Given this list of marker genes FSTL1, ALOX5, HLA-DMA, MYL12A, CBR1, AMOTL2 (angiomotin like 2), VMP1, CFB, CTNNA1, MAPKAP1, DDAH1, EGLN1, SLC40A1, NPNT, MAT2B, C5AR1, COX7B, SH3D19, BTG1, GADD45A, PAH, GM2A, NECAP2, HLA-DRB1, RNPEP, C1R, ARHGAP12, SERPING1, MAOB, CLDN23, TNFRSF21, HLA-C, CAPN6, DUSP4, SPTSSA, ZSWIM6, SDCBP, UQCRH, ANXA2P2, MAP4, KLF5, CNN2, CYBB, TPBG, PTP4A1, SLC20A1, LAPTM4A, UQCRC2, SPSB1, TRIOBP, ACTR2, BRI3, PDLIM1, ZNF208, WWTR1, LBR, CA2, CDR2, EIF4EBP2, ACADVL, JAG1, RNF19A, ATP1A1, C3, TMEM87A, IGF2BP2, TMEM106B, CLDN2, VGLL3, CDKN1A, KLF6, NPAS2, LGALS9, MS4A7, LAMB3 (NCBI Gene Id 3914), FLII, UQCRFS1, ENAH, IMPA2, TFPI, TSHZ2, PIK3AP1, CTTN, TIPARP, COL18A1, CYP51A1, HSPB8, CAPZA1, LPCAT2, ANO6, SLC66A3, ZNF217, SYPL1, BCL10, UBE2L6 (ubiquitin conjugating enzyme E2 L6), RIPK2, CEBPB, CASP10, DCTPP1, RHOC, CHST15, PPIA, TRIM8, CDKN2B, FYB1, FCER1G, MET, YWHAB, EPRS1, IDH2, TMEM41A, TOB2, TMEM132A, AKAP13, FAM133CP, TCP1, FZD5, ERBB3, JPT1, DHRS3, MYL12B (myosin light chain 12B), BCL3, HLA-A, SPATS2L, CTSE, TMEM87B, AFAP1, SETD7, CSRP1, ZBTB20, PKHD1, LAMB1 (laminin subunit beta 1), ADAM10, MALL, CARHSP1, ARL6IP5, CHP1, DDAH2, SPRED1, SERPINA6, MAP3K20, ZNF704, HCK, PDGFD (NCBI Gene Id 80310), TJP2, VAT1, UTRN (utrophin), SLC6A20, CXCL8, PPDPF, IL17RD, GPRC5B, CDK2AP2, ALDOA, TRIP10, CLDN1, ST3GAL1, EZR, TRIM25, CCT2, ARHGAP21, CTSL, ABRACL, SRGN, TMC4, SFRP5, RALA, MSMO1, LACC1, PMP22, NAMPT, PPP1CB, KANK2, KRTCAP3, ANKRD13A, IFI30, IL1R1, UGT2A3, MPRIP, OPTN (NCBI Gene Id 337928), HINT3, SMARCC1, MYD88, EHD4, TINAGL1, SNAP23, ZNF267, HDGF, LURAP1L, IL1RN, CDS1, KNOP1, PACSIN2 (NCBI Gene Id 150377), ITGA6, HADHB, IFITM3, LGALS8, TNS1, NCEH1, YBX3, TGM2, SDS, DGLUCY, SLC25A24, TMEM127, GNS, TMC5, RAC1, SMURF1, MYO1E, CGNL1, EFTUD2, NNT, CNPPD1, BAIAP2L1, EGR1, TUBB6, DUOX2, PTPN14, FAT1, SPNS2, PSMB8, CXCL16, PPP1R11, AKR1C3, SOX10, PRR15L, NDFIP2, ANKRD9, DOCK1, GPX1, CREB5, ID2, BAZ1A, TM2D2, CXCL1, ABHD4, MUC1, TRAK2, REST, MAFF, MGAT4B, CFAP221, PNKD, NFKBIZ, SWAP70, HES1, CDX2, CTBP2, ETS2, SERINC2, TMBIM6, LTB, MSN, TNFAIP3, ACTR3, FGF19, MAPK6, ARPC2, SDHB, TACC1, RERG, ARHGAP29, ACAA2 (acetyl-CoA acyltransferase 2), TCF7L2, CDH1, STK38, ACSS2, CASK, RUNX1, PDE3A, MAP3K21, ATP5F1B, TTC9, FGFR2, ATP5MC3, UGT2B15, S100A13, EIF4E2, TPM4 (tropomyosin 4), KDM5B, CPM, C4orf19, NCOA7, EIF4G2, GLIS3, CRYZ, DIAPH1, ADCY5, NCK2, C1QB, EPCAM, TNFAIP2, RAP2B, AFDN, GULP1, ATP1B1, RAB5B, HEBP2, ANXA1 (NCBI Gene Id 301), SNX6, IGFBP7, SLPI, FTH1, LMNA, PRDX1 (NCBI Gene Id 5052), HLA-F, FGF2, OLR1, ZNF83, SLC35F6, BHLHE40, CEMIP2, RBP1, PPIF, LAD1, DUSP23, CNN3, ELOVL1, CA12, SIAE, ADM, SQSTM1, TMSB10, PDE5A, LIMS1, ITGA2, PTPRK, MRPL15, DYNC1I2, ATP2B4, MYADM, RAC2, HTATIP2, GALNT3, SLC25A5, YAP1, HIP1, HLA-DRA, RAB25, HDHD3, DUSP6, RCAN1, ASAP2, BICC1, UGP2, FLNA, SOWAHC, APBB1IP, FLRT3, CEACAM6, ARPC5, ANXA11, COX5A, HMGCS1, KDSR, TEAD2, AKR1B10, ERRFI1, SPP1, MPEG1, PHLDA1, GALNT2, MAGI3 (membrane associated guanylate kinase, WW and PDZ domain containing 3), APEX1, ACAA1, ATF3, GSTT1, SERPINA5, ZNF117, ERO1A, CRIM1, QSOX1, CAPG, PPARGC1A, STAU1, HNRNPF, ALDH1A3, HEBP1, CFI, SDC1, PBX1, WWC1, SOX9, CLN8, ASS1, SLC34A2, PEA15, DECR1, CEACAM7, PTMA, CDC42EP1, CFTR, ACTG1, FRMD8, BPGM, GOT2, TUBB, TFPI2, TFRC, GSTO1, MYO5B, TFF2, DOK5, RALB, DAG1, COX6A1 (cytochrome c oxidase subunit 6A1), PGK1, B4GALT1, TANC1, ALDH3A2, PRDM16, TGFB2, CSF1, CAP1, HLA-DRB6, KRT7, SULT1C2, SMS, HCP5, TYROBP, DEFB1, TRIM38, F2RL1, WBP2, CFLAR, HPCAL1, RAB32, SYK, CD300A, CLDN4, ARPC3, CLINT1, DCDC2, JCAD (NCBI Gene Id 57608), ITIH5, PIK3IP1, TGFA, BAMBI, RESF1, SEL1L3, CASP4, OSMR, ODC1, ARHGEF40, CYCS, PPIC, NUAK2, VAV3, RPS6KA2, MELTF (NCBI Gene Id 90031), RHOQ, LRATD2, SLC12A2, UGCG, IFNAR1, MIR4435-2HG, S100A10, WDR1, PPP2R3A, HNF1B, TNFRSF11B, ACOT9, MOB3B, SH3BP4 (SH3 domain binding protein 4), IGSF6, GOT1, TNFSF10, CXCL5, DUSP16, AHR, NINJ1, ZNF503, HKDC1, HLA-E, SLC25A23, CD2AP, PLS1, IQGAP1, PTGFRN, DLD, CCDC50, UBALD2, EFNB2, ARHGDIB, CD9, SH3YL1, ARL6IP1, CRP, NCOA4, RAB6A, ARHGAP26, SUSD6, PRR13, SPAG1, DAZAP2, LAPTM4B, GCC2, ZDHHC3, TIMP3, ANXA5, RNF44, CCN1, B3GNT7, TAPBP, DHCR24, TTL, LGALS4, TMEM98, AGAP1, DUSP5, GSN, SEMA6A, LEPROT, EXT1, TLE1, SH3BGRL3, STK38L, RCC2, RETSAT, TNFRSF1B, OCLN, GUCD1, PDLIM3, KCNK5 (potassium two pore domain channel subfamily K member 5), NTN4, CTTNBP2NL, C1QC, SYNE2, WASHC4, ZDHHC7, TNFRSF10B, AGT (angiotensinogen), HLA-DMB, HSD17B11, MINDY2, LGALS3BP, XRN2, IGSF3, LDHA, SEPHS2, KCNJ15, DTX3L, EPS8L3, CYP3A5, PPFIBP1, NHERF1, ABTB2, DSC2, FAM171A1, ANXA3, VASN, SFPQ, G6PC1, TPI1, MUC20, CPPED1, NHSL3, MGST3, VAMP8, GJA1, SESTD1, HMGB1 (high mobility group box 1), ASAH1, PLSCR1, SLC17A4 (solute carrier family 17 member 4), ZFP36L1, PNP, NRAS, TGFBR2, CYFIP1, BTBD7 (NCBI Gene Id 55727), PFKP, MID1, TIMP2, NEAT1, CCDC198, SLA, SYT8, EPB41L1, CRYBG1, KLHL24, CTSS, RSU1, TM4SF1, ITGB5, STK17B, LMO7, ONECUT2 (one cut homeobox 2), TRIB1, NPC2, ADGRF1, ITGA3, CXCL2, SMC5, TUBB4B, LMO4, GADD45B, MTUS1, B3GNT5, PRSS23, STARD7, CYP1A1, C6, HMGN1, HLA-DQA1, CFH, ARHGEF18, LYPD1, CAPN2, HNRNPAB (NCBI Gene Id 3182), WFDC2, SLC39A1, LRRFIP1, GATM, MMP7, CXADR, DYNLT1, LRRC8A, LCN2, PFN1, GBP2, FRMD4A, MAL2, C1RL, ARL4C, PTTG1IP, KCNQ1, TXN (thioredoxin), PTAFR, NDUFS2, EDN1, GSTK1, KRT80, GALNT7, ABCC4, GJB1, GMNN, C1QA, RASEF, LPAR6, PIGR, ZFP36L2, PTPRM, RB1CC1, ARF6, UBAP1, PGM2L1, CTSB, GDF15, POF1B, ABI1, MITF, CCNG2, RHOU, PAIP1, SATB1, WDR72, RHBDF1, TACSTD2, RDH11, TMEM165, NARS1, SDC4, GNPTAB, LUZP1, TBXAS1, CXCL3, ARSD, CLMN, ALDH3B1, KIAA1217, ACP5, CCND1, IER5, FUCA1, GSTM4, MCL1, AKAP7, ERGIC1, RPS27L, FNDC3B, CAV1, STAB1 (NCBI Gene Id 23166), ETV6, EIF2S3 (NCBI Gene Id 8422), SYNPO, PTPN12, CCL20, FCER1A (NCBI Gene Id 2205), MYO10, SLC38A1, TPGS2, CD47, ATP5F1C, MLPH, EGFR, SUCLG2, LINC01133, NECTIN2, SNHG12, NFKBIA, CDK6, TC2N, OCIAD2, FUT4, CCN2, SAV1, MBD2, CYP4V2, VASP, TNFSF15, CRCT1, TRIM47, SERINC5, VCAM1, ABCB1, CCL28, RCN2 (reticulocalbin 2), PSMB10, VNN1, CDR2L, PTPRC, ATP8B1, SNX10, TSPAN14, ZFP36, CHMP2B, CLIC1, YWHAZ, CD68, XRCC5, SAMD9, SLC12A7, RBM47, RAB10, LAMA5, HSPA1A, FILIP1L, CASP7, JOSD1, TM7SF3 (transmembrane 7 superfamily member 3), CAV2, STAT6, OLFM4, SLC3A1, SRGAP1 (NCBI Gene Id 57522), MTMR12, KRT18, PTMAP11, TGIF1, LPGAT1, THSD4, IFI16, ACTN4, DERL1, ALOX5AP, SERPINA1, LYN, AKR1C1 (NCBI Gene Id 9418), NRP1, HABP2, PGM2, ABCA1, SERPINB2, TPSAB1, LCP1, SMAD3, FA2H, RAPGEF5, H3-3B, SERTAD2 (SERTA domain containing 2), RASSF4 (Ras association domain family member 4), CD44, LRP10, PDCD6IP, SGPP1, NEURL3, APCS, PLA2G7, KRT19, LHFPL2, EEIG1 (estrogen-induced osteoclastogenesis regulator 1), CD74, NDRG2, GLO1, PAK1, CDH6, PSAP, NFIA, PWWP3B, CCL3 (C-C motif chemokine ligand 3), B4GALT4, CTNNB1, ADGRG6, RHOB, ABHD2, TAGLN2, ITPR2, ATP11A, AMOTL1, TGFBI, HLA-DPB1, APP, APOL1, CCDC71L, C1orf116, ITGB1, CHML, TST, CANT1 (NCBI Gene Id 619513), LAMC2, LIMA1, PMEPA1, FAHD1, ADGRA3, GLB1, LGALS3, ELOVL7, VDAC1, TOP2B, A2M (alpha-2-macroglobulin), LRG1, CTSO, ACSS1, H19, IL6ST, ADAM28, CEACAM5 (NCBI Gene Id 1048), VSIG4, RHOG, MYO1C, S100A14, HEG1 (NCBI Gene Id 57493), AHNAK, DHRS7, INSIG2, NR5A2, EIF6, EBP, NET1, SH2D4A, VCL, NTRK2, TMPRSS2, ANXA4, ERBIN, SLC44A2, SCNN1A, SYNCRIP, CITED4, GLUL, KRT17, CSTB, TP53INP2, ALAD, RMND5A, ARHGAP18, MACC1 (MET transcriptional regulator MACC1), NCAM1, TSPAN8, NMT2, CALD1, HOMER2, MDK, ATP11B, MARCKSL1, TRIM26, RAB27B, KRT23, SLC16A7, ERICH5, KIT, EFNA1, DDIT4 (NCBI Gene Id 54541), JUN, NR0B2, PLAU, TES, PDGFC, CBX3 (chromobox 3), SP100, TUBB3, DCBLD2, TP53I11, TXNIP, WSB1, THBS1, IFIT3, NFE2L2, KRT8, PHLDA2, MYOF, NDUFA6, CD24, RNASET2, SCAF11, SPTAN1, FGFR3, HS3ST1 (NCBI Gene Id 9957), TMEM50A, AQP1, RNASE1, RASSF8, GATA6, GRB2, LITAF, STS, DST, MAP1LC3B, PIM1, TOP1, SDHA, TUBA1C, SINHCAF, CHD4 (NCBI Gene Id 1108), FH, GYPC, WNK2, ATP13A3, IGF2R, LAPTM5, CFL1, FARP1, SLC46A3, ITGB2, TFF1, PROM1, HADHA, LLGL2, ABCC3, FNDC4, SKIL, MPC1, SP1 (NCBI Gene Id 6667), TMBIM1, LGR4, HLA-DQB1, PSME3, TBC1D16, TTN, BACE2 (NCBI Gene Id 25825), SIPA1L1, WEE1, F11R, TNFAIP8, HBEGF, LYPLA1, NECTIN4, AGPAT3, RNF213, GDE1, APCDD1 (NCBI Gene Id 85500), ENC1, MGAT5, ABCF1, CLIC4, CD63, PTPRF (NCBI Gene Id 5792), PLAUR, ADAM9 (NCBI Gene Id 8754), CHI3L1, SAT1, HGSNAT, STK24, ID3, CAT, PERP, PRKCA, PLS3, IFNGR2, MYH9, NFIX, NIPSNAP2, KLF13, MPZL1, DAPK1, CD84, TNKS1BP1, LIPH, RNF103, ABHD11, NEXN, FMNL2, MYH14 (NCBI Gene Id 79784), AMBP, BAAT, LIPA, PTP4A2, MSR1, UBD (ubiquitin D), SLC1A1, EPHA2 (EPH receptor A2), CAST, LMAN2, APOL6 (apolipoprotein L6), NCL, SLK, B4GALT5 (beta-1,4-galactosyltransferase 5), FAM110C, ALDH2, SUCLG1, ARPC1B, KIF13B, SRP14, SPTBN1, CTSC, C1S, NR1H4, FGD6, IFITM2, HNMT, HLA-DPA1, LAMC1, OXSR1, TUT7, ACSL4, ANK3, RAB9A, SORBS2, S100A6, CMTM7, SYNGR2, TNFRSF12A, CYC1 (cytochrome c1), C1orf198, LAMP2, SPRY2, NR2F2 (NCBI Gene Id 7026), SPINT1, TPM1, ERLIN2, MUC13, IQGAP2, NFIB, PLXNB1, FLRT2, ATP10B, TMEM43, IL18, PDLIM5, MLEC (NCBI Gene Id 9761), LIF, EHF, PDZK1IP1, PDP1, GBP3, FGA, KIF1C, PLEKHA2, STOM, CTSD, OGA, TMSB4X, ST6GAL1, RDH10 (NCBI Gene Id 157506), DUSP1, ICAM1, SOD2, CSF1R, BDH2, HDAC7, HSD17B2, TMOD3 (NCBI Gene Id 29766), VTCN1, LBH, ARRB2, NDUFA4, TP53BP2, NEDD9, COX5B, IER2, FDFT1, ARHGEF12, CES1, BCL2, HEXB, PON2, PAWR, RALGAPA2, HK1, NIBAN2, EPS8, LPP, NOTCH2, CYP1B1, MYRF, ANKRD1 (ankyrin repeat domain 1), SLC4A4, ELF3, STX7, UPK1B, NCF2, AGR2, NEDD4L, PAK2, SHROOM3, RRAS2, LANCL1, ABHD3, RBPMS, SLC38A2, GSTP1, ETFA, LASP1, FBLIM1, GPX2 (glutathione peroxidase 2), CERS2, MAGI1 (membrane associated guanylate kinase, WW and PDZ domain containing 1), NOP10, NLN, RGS1, NOTCH2NLA, APLP2, CXCL6, IL10RB, ELF1, PAFAH2, CMTM3, CNDP2, GNG5, RND3, KLF3, CD59 (CD59 molecule (CD59 blood group)), PFKFB3, ITGB4, PARD6B (NCBI Gene Id 84612), STK17A, GPNMB, VDAC2, MACF1, HSD11B2, PARD3, ITGB8, EXOC6, SIRPA, TSPAN15 (tetraspanin 15), CALM2, RAB11FIP1, S100A11, PHLDB2, TMEM51, CYTH2, PLEKHB1, CPT1A, SOX4, PIGS, TTYH3, QKI, DAB2, CREG1, BIRC3 (NCBI Gene Id 330), RUNX3, ITGAV, SLC35B2, PCSK5, MCAM, TMEM123, PICALM, SERPINA3, PRSS22, ADI1, CASP6, CLDN10, CCL2 (NCBI Gene Id 6347), CIAO2A, TSPAN3, RNF128, ALKAL2, PSG4, ZYX, ANXA2, GRN, ANXA9, PARP4, PIK3R1, MYO6, CCDC6, PNRC1, LDLR, FTH1P3, FGL2, BMP2, TBC1D5, BZW1, B2M, CRYAB, DSG2, CD151, LAMA3, ADAMTS9, PARP14, NGFR, ZNF292, MST1L, CTSH, HLA-B, KLHL5, SLC44A4, CCN3 (cellular communication network factor 3), NAPG, ZC3H12A, ATP5PO, CDH19, ACTB, GALNT1, KCNJ16, NAGK, TNS3 (tensin 3), CMPK1, KIAA0930, CS, HIF1A, JUP, SVIL, PRKX, GCNT3, SLFN5, BCL6, CAPN1, VPS26A, TCIM, DDX52, CLDN7, PLD1, UCA1, PPP1R18, SLC43A3, TXNRD1, CD53, PCYOX1, SLC15A1, IL4R, SLC25A3, CD276, ADAMTS1, ATP5F1A, OSBPL1A (oxysterol binding protein like 1A), SLC28A3, TPD52L1, GOLM1, FOXO3 (forkhead box O3), PXDC1, RHPN2, PKP4, CX3CL1, S100A16, GNG12 (G protein subunit gamma 12), COX7C, SAMD12, TXNDC17, TRPV6, DAB2IP, TMT1A, C12orf75, ID1, LATS2, UBC, TJP1, HSPB1, OLFML2A, ENO1, PRXL2B, PDHA1, MAP3K1 (NCBI Gene Id 4214), PATJ (PATJ crumbs cell polarity complex component), PDIA5, CPA3, SH3PXD2B, TSPAN6, MDH1, LYZ, PHB1, IER3, WLS, PNPLA2, here is a description of the gene set: Human Gene Set: MURARO_PANCREAS_DUCTAL_CELL species: Homo sapiens from publication Muraro MJ, Dharmadhikari G, Grün D, Groen N, Dielen T, Jansen E, van Gurp L, Engelse MA, Carlotti F, de Koning EJ, van Oudenaarden A (PMID 27693023)